The following is a description of a gene set: Human Gene Set: GOCC_EXTRINSIC_COMPONENT_OF_POSTSYNAPTIC_MEMBRANE studied in species Homo sapiens The component of the postsynaptic membrane consisting of gene products and protein complexes that are loosely bound to one of its surfaces, but not integrated into the hydrophobic region., and this is the list of marker genes: CTNNA2, SCRIB (NCBI Gene Id 23513), CNKSR2, CRKL, AKAP9, PPP1R9B, C1QC, FGF22, C1QA, VWC2, FARP1, FBXO2, RNF10